Given this list of marker genes DICER1, SEC23B, EP300, APC, KMT2D, MLH1, GJB2, WNT10A, FLCN, KEAP1, PTEN, KDM6A, CTNNB1, CREBBP, MAD1L1, KLLN, GJB6, MSH2 (NCBI Gene Id 8169, mutS homolog 2), here is a description of the gene set: Human Gene Set: HP_SKIN_APPENDAGE_NEOPLASM Skin appendage neoplasm studied in species Homo sapiens A benign or malignant neoplasm that arises from the hair follicles, sebaceous glands, or sweat glands.